The following is a description of a gene set: Antimicrobial peptides (AMPs) are small molecular weight proteins with broad spectrum of antimicrobial activity against bacteria, viruses, and fungi (Zasloff M 2002; Radek K & Gallo R 2007). The majority of known AMPs are cationic peptides with common structural characteristics where domains of hydrophobic and cationic amino acids are spatially arranged into an amphipathic design, which facilitates their interaction with bacterial membranes (Shai Y 2002; Yeaman MR & Yount NY 2003; Brown KL & Hancock RE 2006; Dennison SR et al. 2005; Zelezetsky I & Tossi A 2006). It is generally excepted that the electrostatic interaction facilitates the initial binding of the positively charged peptides to the negatively charged bacterial membrane. Moreover, the structural amphiphilicity of AMPs is thought to promote their integration into lipid bilayers of pathogenic cells, leading to membrane disintegration and finally to the microbial cell death. In addition to cationic AMPs a few anionic antimicrobial peptides have been found in humans, however their mechanism of action remains to be clarified (Lai Y et al. 2007; Harris F et al. 2009; Paulmann M et al. 2012). Besides the direct neutralizing effects on bacteria AMPs may modulate cells of the adaptive immunity (neutrophils, T-cells, macrophages) to control inflammation and/or to increase bacterial clearance.<p>AMPs have also been referred to as cationic host defense peptides, anionic antimicrobial peptides/proteins, cationic amphipathic peptides, cationic AMPs, host defense peptides and alpha-helical antimicrobial peptides (Brown KL & Hancock RE 2006; Harris F et al. 2009; Groenink J et al. 1999; Bradshaw J 2003; Riedl S et al. 2011; Huang Y et al. The module includes also proteolytic processing events for dermcidin (DCD) and cathelicidin (CAMP) that become functional upon cleavage. In addition, the module highlights an AMP-associated ability of the host to control metal quota at inflammation sites to influence host-pathogen interactions. part of: Innate Immune System Reactome Pathway: Antimicrobial peptides species: Homo sapiens, and this is the list of marker genes: DEFB129, DEFB106A, RNASE7, DEFB107A, CTSG, DEFB1, EPPIN, S100A7A, LYZ, CCR2, DEFB108B, S100A9, SEMG1, DEFB127, CHGA, BPIFB6, PRSS3, DEFB113, DEFB130B, DEFA6, DEFB130A, PDZD11, DEFB108A, DEFB131A, ATP7A, DEFB124, TLR1, DEFB105A, RNASE8, CLU, DEFB121, DEFB117, DEFA4, DEFB114, DEFB118, HTN3, DEFB110, RNASE3, SLC11A1, PGLYRP2, BPIFA2, DEFB128, CCR6, REG3G (regenerating family member 3 gamma), BPIFA1 (NCBI Gene Id 51297), HSP70, ATOX1, BPIFB2, DEFA1, DEFB104A, BPIFB4, BPI (bactericidal permeability increasing protein), SSA2, DEFB125, DEFB116, ITLN1, PGLYRP4, DEFB132, HTN1, TLR2 (toll like receptor 2), DEFB135, DEFB134, PLA2G2A, DEFB126, REG3A, PRTN3, S100A8, S100A7, DEFB115, GNLY, CAMP, LCN2, LTF, ART1 (ADP-ribosyltransferase 1), DEFB109B, DEFA5, DEFB112, LEAP2, BPIFB1, DEFB133, PGLYRP1, env, PRSS2, DEFB119 (NCBI Gene Id 245933), CD4, DEFB136, ELANE, DEFA3, PI3, DEFB103A, PGLYRP3, DCD, DEFB123, RNASE6, DEFB4A